Given this list of marker genes HMX1, PIGL, MKS1, KDM6A, CEP120, RAB3GAP1 (NCBI Gene Id 338380), DHX38, INPP5E, TBC1D20, PRPS1, B3GLCT, ALDH1A3, INTS1, RAB3GAP2, MMACHC (metabolism of cobalamin associated C), FIBP, C2CD3, FGF3, SALL2 (spalt like transcription factor 2), RAP1B, CRB1, SPATA7, AHI1, RPE65, MAN2C1, CEP290, KIAA0586, NMNAT1, RAB18, CLDN19, CEP41, TENM3, CASK, FZD5, TFAP2A, LRAT, ZEB2, KMT2D, PAX2, PUF60 (poly(U) binding splicing factor 60), CHD7, LCA5, SALL4, here is a description of the gene set: Human Gene Set: HP_RETINAL_COLOBOMA studied in species Homo sapiens Retinal coloboma A notch or cleft of the retina.